The following is a description of a gene set: species: Homo sapiens Any process that stops, prevents, or reduces the frequency, rate or extent of translational initiation. Human Gene Set: GOBP_NEGATIVE_REGULATION_OF_TRANSLATIONAL_INITIATION, and this is the list of marker genes: ZNF598, EIF4EBP2, EIF2AK1, EIF2S1, PAIP2B (NCBI Gene Id 57218, poly(A) binding protein interacting protein 2B), EIF3E, EIF2AK3, EIF2AK4, RBM4, EIF4E2, RPL13A (NCBI Gene Id 94020), C8orf88, AGO2, PML, ATF4, TPR, FMR1, GIGYF2, HHEX, BANK1, LARP1, EIF4EBP1, EIF4EBP3, PAIP2, SCRIB